Given this list of marker genes MAP2, RAG1, EHD4, RABIF, FERMT1 (NCBI Gene Id 55612), ZNF681, XRN2, RFX7, PPM1B, TGFBR1, ABCG4, EDEM3, SPPL2A, BMP3, KLF3, PSIP1, DENR, PIK3CA, FAM118B, RPRD1A, TBX21, P3R3URF-PIK3R3, FECH, ZNF664, CDKL5, PAPOLA, ERRFI1, MON2, RELCH, IPO7, MAGI3, NEUROD1, KCTD15, BCLAF3, LGI1, LPIN2, HECTD1, UBE2L3, ITGAV, PPP2CA, SLITRK1, FXR2, MSN, UBR3, MYH8, PTPRK, RSBN1, IQCJ-SCHIP1, DNMT3A, ARHGEF7, EPDR1, SORCS3, GSK3B (glycogen synthase kinase 3 beta), SGIP1, CADPS, CENPQ, GJC1, FHL1, STAG2, UBE2E1 (NCBI Gene Id 94682), RNF180, ORMDL3, CNTN4, DENND5A, MMGT1 (NCBI Gene Id 93380), TAF2, EGLN1, FUT1, DNAJC6 (DnaJ heat shock protein family (Hsp40) member C6), MYBL1, OSBP2, JAKMIP2, HOXD1, RARB, PTPRD, EMC2, HS3ST1, PAG1, ADAM10, PSD3, CRACD, RAB7A, DIP2B, FARP1, DACH1, BOLL, IKZF2, TANC2, LGALSL, MED13L, EIF3J (NCBI Gene Id 8669), C15orf61, ZBTB21, DESI2, GSTA5 (glutathione S-transferase alpha 5), BNC2, TMCC1, FOXJ3, KNSTRN, CFAP53, GRID2, GTF2E1, SLC40A1, RAB11FIP2, SHTN1, TENM3, TTC14, WDR47, RASSF8, PIK3R3, HIPK3, ZNF536, ABTB3, GRIA2, DONSON, ST6GALNAC3, PAPOLG, SPIDR, TASOR2, NPTN, NBR1, SLC9A6, CSMD2, CCN3, ANKIB1, TRIM5, here is a description of the gene set: Genes predicted to be targets of miRBase v22 microRNA hsa-miR-1183 in miRDB v6.0 with MirTarget v4 prediction scores > 80 (high confidence targets). from publication Chen Y, Wang X (PMID 31504780) studied in species Homo sapiens Human Gene Set: MIR1183